The following is a description of a gene set: Mouse Gene Set: GOBP_DEADENYLATION_DEPENDENT_DECAPPING_OF_NUCLEAR_TRANSCRIBED_MRNA Cleavage of the 5'-cap of a nuclear mRNA triggered by shortening of the poly(A) tail to below a minimum functional length. studied in species Mus musculus, and this is the list of marker genes: Dcp2, Pan3, Caprin1, Dcp1a, Cnot7, Lsm1, Dcps, Patl2, Eif4enif1, Dcp1b, Noct, Patl1